The following is a description of a gene set: species: Homo sapiens Caudate atrophy Human Gene Set: HP_CAUDATE_ATROPHY, and this is the list of marker genes: ASNS, VPS13A, NDUFAF5, HTT, LONP1, BSCL2, TIMM8A, OPHN1, FOXP2, FTL (ferritin light chain), NEK1, JPH3, SLC2A3, TYROBP, TREM2